The following is a description of a gene set: Human Gene Set: WP_TYPE_I_INTERFERON_INDUCTION_AND_SIGNALING_DURING_SARSCOV2_INFECTION Type I interferon induction and signaling during SARS-CoV-2 infection studied in species Homo sapiens, and this is the list of marker genes: IFNAR2, RIGI, OAS2, TLR7, MYD88, TRAF6, TREML4, TLR6, IRAK4, IRF3, IFNAR1, TLR4, TLR3, IRF7, TLR2, JAK1, STAT2, IFIH1, TMPRSS2, EIF2AK2, IKBKE (NCBI Gene Id 9641), ACE2, IRF9, OAS3, TBK1 (TANK binding kinase 1), TYK2, TRAF3, OAS1, TLR9, STAT1, MAVS